The following is a description of a gene set: Mouse Gene Set: MIR_217_3P studied in species Mus musculus Genes predicted to be targets of miRBase v22 microRNA mmu_miR_217_3p in miRDB v6.0 with MirTarget v4 prediction scores > 80 (high confidence targets). from publication Chen Y, Wang X (PMID 31504780), and this is the list of marker genes: Sun1, Nckap1, Arl3, Gpr141b (NCBI Gene Id 319293), Dbt, Spopl, Cntn1, Pdcd6ip, Stx8, Tacr1, Ccnb3, D5Ertd579e, Kbtbd8, Patj, Slc41a1, Col5a2, Ogt, Kpnb1, Sv2b, Rbfox1, Cald1, Gpr37, Pank3, Slc18a2, Gucy2f, Atad2, Sh3gl3, Ccn2, Sh3bgrl, Usp25, Igf2, Zfp985, Appl1, Zdhhc20, Ugt2a2, Yipf6, Ptges3, Asb3, Eea1, Or7d10, Fam161b, Eloc, Slbp, Xkr4, Pkia, Smarcd1, Cabyr, Cbx5, Hnrnpu, Ugt2a1, Map4k3, Pde3b, 1700017N19Rik, Adam12, Mllt3, Zbtb10, Jmjd1c, Cse1l, Vkorc1l1, Spry2, Myef2, Igf2bp2, Zfp148, Tmem144, Mylk, Aspn, Wls, Mycbp2, Dnajc6, Fzd3, Dhdds, Cenpc1, Usp16, Hipk1, Lyve1, Lima1, Zc3h11a, Dnaja1, Hoxc6, Adam18, Meioc, Zfp746